Given this list of marker genes Ces3b, Apoc4, Ldlr, Lipc, Apoe, Apoc1, Ces3a, Ap2m1, Lipa, Nceh1, Ap2b1, Ap2a1, Apob, Vldlr, Apobr, Apoa1, Ap2s1, Rps27a, Ubb, Npc2, here is a description of the gene set: Reactome Pathway: Plasma lipoprotein clearance species: Mus musculus electronically inferred by orthology from the curated human pathway This event has been computationally inferred from an event that has been demonstrated in another species.<p>The inference is based on the homology mapping from PANTHER. Briefly, reactions for which all involved PhysicalEntities (in input, output and catalyst) have a mapped orthologue/paralogue (for complexes at least 75% of components must have a mapping) are inferred to the other species. part of: Plasma lipoprotein assembly, remodeling, and clearance